Given this list of marker genes C8G, F12, MAT1A, HSD17B6, VTN, CYP2E1, CYP2A6, ETFB, ZGPAT, SERPIND1, CYP2C9, PCK2, SERPING1, AHSG, QPRT, HPD, APCS (amyloid P component, serum), APOC1, CES1, GSTM1, ITIH1, F10, ANG, ALDH1L1, CES2, ASGR2, FAH, HAMP, ADH1C, TST, PXMP2 (peroxisomal membrane protein 2), APOC3, ASL, ATF5, KHK, DCXR, SLC22A7, TKFC, TMEM176A, ALDH4A1 (NCBI Gene Id 8659), CYP2B6, IGFALS, HP, SLC22A1, GNMT, PKLR, SERPINA4, ORM2, UPB1, RDH16, RARRES2, APOC2, HGFAC, ACOX2, CYP4A11, LCAT, CIDEB, ORM1, SAA4, SERPINF2, SDS, PON3 (NCBI Gene Id 94886), FTCD, CYP2D6, SLC27A5 (NCBI Gene Id 22942), TFR2, AKR7A3, GSTM2, CYP2C8, ECHS1, SERPINC1, GAMT (guanidinoacetate N-methyltransferase), PON1, NNMT, CDHR5, CYP1A2, CYP4F2, HRG, HABP2, SARDH, AMBP, RBP4, GSTZ1, CEBPA, AGXT, APOC4, ANGPTL8, HPX, ITIH3, HPN, HMGCL, TMEM176B, PROC (protein C, inactivator of coagulation factors Va and VIIIa), ALDOB, HMGCS2, ITIH4, PCK1 (NCBI Gene Id 5105), TAT, SLC38A3 (solute carrier family 38 member 3, NCBI Gene Id 10991), F2, APOA1, ABCC6, CYP27A1, CYP4F11, here is a description of the gene set: Neighborhood of TST Human Gene Set: GNF2_TST Neighborhood of TST thiosulfate sulfurtransferase (rhodanese) in the GNF2 expression compendium species: Homo sapiens